Given this list of marker genes ZIK1, CDKN2C, THEMIS2, MRPL3, GAB1, SEMA4A, ZBTB12 (zinc finger and BTB domain containing 12), AMZ2, TSPYL4 (TSPY like 4), LY86, SERPINB1, QNG1, XRCC6, CLDN7, SEPTIN6, TRAPPC2L, TLCD2, PDGFB (platelet derived growth factor subunit B), FOXF2, PARP12, SEC61B, RPA3, HS1BP3, SH3KBP1, RASSF9, FZD5, NREP, RABIF, TCOF1, ATOX1, CSNK1G1, TIMM10, SIVA1, DYNLL1, ARHGEF2, MYO1F, SEMA4D, TRIM7, SCFD1, CYP2F1 (NCBI Gene Id 1572), IPO11, DLK1, CXCL11, DGKG, APLN (apelin), SDHD, BTK, LSM10, TM9SF1, PLAGL1, CBFA2T2, PCSK6 (proprotein convertase subtilisin/kexin type 6), MEOX2, FAM110A (NCBI Gene Id 83541), AP1M1, FGR, PILRB, MIS18A, WNT11, RGS2, RPS26, TM4SF1, AKR1B1, SPI1, TTC8, TYROBP, MDM1, INTS3, RPS11, RMND1, TMEFF1, DDX41, PDLIM1, H2AZ1, MRPS28, EPHA1, FOLR2, VEGFA, FZD2, QRICH1, PSMD5, BNIP3L (BCL2 interacting protein 3 like), HNMT, UTP20, MYLIP, CLCN5 (chloride voltage-gated channel 5), ASB7, IMMP1L, HACD4, TRIM47, YPEL5, IFITM3, PSTK, ORMDL1, SQOR, UNC5B, MC5R, FZD1, UROS, TNFRSF13B, TNFRSF19, FGF18, MYO1G, ENSG00000286190, CD177, EFNA1, GSAP, CFAP68, GRK6, LMNA, EVPL (NCBI Gene Id 2125), CAMK2G, NAA38, CDH23, CAVIN3, YIF1A, AIF1, S100A13, PIM2, SMIM8, DNA2, RECQL4, TOX, SNAI2, KCNH2, GLIS2, DACT1, FAM43A, DCTN6, PPFIBP2, RAB38, ESRRB, JPT1, GPRC5B, PRPF19, TMPRSS2, TDRP, ILF3, MAPK7, PLD4 (NCBI Gene Id 414770), LYN, PALMD, PSTPIP1, APPL1, PKP2, CSF1, ELP5, POLR2A, FCRLA, TUBD1, B3GNT5, LATS1, MTX2, ATP5IF1, CXCR4, MYB, SLC25A45, HADH, HAUS2, MPP1, GASK1B, ANO1, KRT23, VANGL1, NDUFB9, NUP62, PSMA2, WNT7A, KRCC1, TM4SF5, DOCK7, CNOT2 (CCR4-NOT transcription complex subunit 2), ST13, TCTA, SAE1, TPP2, TRABD, LIMD2, MAGED1, GPSM2, MRPS14, CRIP1, FMNL3, ANP32A, KEL, DHRS11, MS4A6A, DAD1, SSBP3, TAGLN2, FOXA2, C3orf70, MGLL, LY96, RPL6, CNR2, DNMT1, EVI2B, RCAN3, SRC, here is a description of the gene set: species: Homo sapiens Human Gene Set: GSE20715_0H_VS_6H_OZONE_LUNG_UP Genes up-regulated in comparison of lung tissue from wild type mice subjected to ozone for 0 h versus that from wild type mice subjected to ozone for 6 h. We previously identified toll-like receptor 4 (Tlr4) as a candidate gene responsible for ozone (O3)-induced pulmonary hyperpermeability and inflammation. The objective of this study was to determine the mechanism through which TLR4 modulates O3-induced pulmonary responses and to utilize transcriptomics to determine TLR4 effector molecules. C3H/HeJ (HeJ; Tlr4 mutant) and C3H/HeOuJ (OuJ; Tlr4 normal), mice were exposed continuously to 0.3 ppm O3 or filtered air for 6, 24, 48 or 72 hr. Affymetrix Mouse430A_MOE gene arrays were used to analyze lung homogenates from HeJ and OuJ mice followed using a bioinformatic analysis. Inflammation was assessed by bronchoalveolar lavage and molecular analysis by ELISA, immunoblotting, and transcription factor activity. TLR4 signals through both the MYD88-dependent and independent pathways in OuJ mice, which involves MAP kinase activation, NF-kappaB, AP-1, and KC. Microarray analyses identifiedTLR4 responsive genes for strain and time in OuJ versus HeJ mice (p<0.05). One significantly upregulated cluster of genes in OuJ were the heat shock proteins (Hspa1b; Hsp70), Hsp90ab1). Furthermore, O3-induced expression of HSP70 protein was increased in OuJ compared to HeJ mice following 24-48 h O3. Moreover, BAL polymorphonuclear leukocytes (PMN) and total protein were significantly reduced in response to O3 in Hspa1a/Hspa1btm1Dix (Hsp70-/-) compared to Hsp70+/+ mice (p<0.05). TLR4 signaling (MYD88-dependent), ERK1/2, AP-1 activity, and KC protein content were also significantly reduced after O3 exposure in Hsp70-/- compared to Hsp70+/+ mice (p<0.05). These studies suggest that HSP70 is involved in the regulation of O3-induced lung inflammation through the TLR4 pathway and provide evidence that HSP70 is an endogenous in vivo TLR4 ligand. from publication Bauer AK, Rondini EA, Hummel KA, Degraff LM, Walker C, Jedlicka AE, Kleeberger SR (PMID 21543283)